Given this list of marker genes Kpna2, Trim15, Kpna6, Bst2, Fmr1, here is a description of the gene set: The directed movement of a virus, or part of a virus, into, out of, or within a host cell. species: Mus musculus Mouse Gene Set: GOBP_TRANSPORT_OF_VIRUS